The following is a description of a gene set: Human Gene Set: MIKKELSEN_MEF_ICP_WITH_H3K27ME3 Somatic cells can be reprogrammed to a pluripotent state through the ectopic expression of defined transcription factors. Understanding the mechanism and kinetics of this transformation may shed light on the nature of developmental potency and suggest strategies with improved efficiency or safety. Here we report an integrative genomic analysis of reprogramming of mouse fibroblasts and B lymphocytes. Lineage-committed cells show a complex response to the ectopic expression involving induction of genes downstream of individual reprogramming factors. Fully reprogrammed cells show gene expression and epigenetic states that are highly similar to embryonic stem cells. In contrast, stable partially reprogrammed cell lines show reactivation of a distinctive subset of stem-cell-related genes, incomplete repression of lineage-specifying transcription factors, and DNA hypermethylation at pluripotency-related loci. These observations suggest that some cells may become trapped in partially reprogrammed states owing to incomplete repression of transcription factors, and that DNA de-methylation is an inefficient step in the transition to pluripotency. We demonstrate that RNA inhibition of transcription factors can facilitate reprogramming, and that treatment with DNA methyltransferase inhibitors can improve the overall efficiency of the reprogramming process. studied in species Mus musculus from publication Mikkelsen TS, Hanna J, Zhang X, Ku M, Wernig M, Schorderet P, Bernstein BE, Jaenisch R, Lander ES, Meissner A (PMID 18509334) Genes with intermediate-CpG-density promoters (ICP) bearing the tri-methylation mark at H3K27 (H3K27me3) in MEF cells (embryonic fibroblasts)., and this is the list of marker genes: SLC38A5, ART3, HOXB3, TNF, TJP3, CLDN9, RGS8, C1QA, TFAP2B, LEFTY1, SLITRK1, SPATA3, UPK2, CFC1B, EPCIP, PDE11A, KCNIP2, QPRT, CRIPTO, PKHD1L1 (PKHD1 like 1), NCAN, ALOX15B, NKX2-6, BICDL2, ESRP1, UPK3A, HEPACAM2, LTA, SLC24A1, UCP1, COL4A4, C6orf15, LINGO4, FAM149A, CKMT1B, CFAP95, CD72, NOTO, ZIC4, OR2B11, RLN2, MST1, DLG2 (discs large MAGUK scaffold protein 2), SCN9A, KCNJ5, PAMR1, CD40, MOGAT1, RESP18 (NCBI Gene Id 389075), GDAP1L1, PDE1C, SLC28A3, PNOC, ZDHHC22, PLCXD3, ADAMTS16, PVALB, GRB7, CA3, KCND2, MTCL3, ERICH5, NOXA1, CHDH, SULT2B1, NCCRP1, NR5A2, TTLL6, CIITA, BSX, EGF, SOX17, VTN, TNFRSF13C, LRRC23, SLC38A11, EXPH5, PHACTR1, TMEM45B, ODAD1, AQP2, PM20D1, LRRC36, DNAJB13, NPHS1, CHRNG, TMEM184A (transmembrane protein 184A), ARHGAP9, PAX5, GUCA1ANB-GUCA1A, GIPR (NCBI Gene Id 2696), KCNJ9, AQP6, ETV2, SPINT4, ISLR2, KCNMB2, VRTN, CPLX3, LY6G6C, SCN1A, LRRC4B, RYR1, CFAP65, NR5A1, FAIM2, GNAT1, COL4A3, ABCC3, GALNTL6, ADGRG7, CYP1A2, EPN3, C17orf50, ALPI, RASGRP4, ENTPD3, C11orf87, RTBDN, BRINP3, NPY4R, AHSG, PNMA8A, C5, KCNK10, TRIM15, THSD4, ZNF663P, APOA4, LY6G6E, PRR19, ESPN (NCBI Gene Id 83715), CA14, MEF2B, CDH12, SYT3, PIK3CD, TBX22, SLC9A4, FXYD7, SLC25A41, TYMP, NPVF, NSG2, TBATA, KCNN3 (potassium calcium-activated channel subfamily N member 3), FFAR3, LPO, TMEM232, DKK1, STRA6LP, NFE2, GPR84, NRL, PCDH12, FGR, LRRC43, POU2F2, WFDC10A, AVPR1B, TNK1, TDRD1, ATCAY, MALL, HJV, OLAH, MYBPC2, PHYHIP, CALCB, SMTNL1, SYBU, C11orf97, ANKMY1, WNT8B, ELMO1, CD3D, CUTALP, MIOX, TMEM63C, SEZ6L2, GRM3, CHRNB4, HOXB13, SPACA7, KLB, CNTNAP4, NME8, SLFN5, GAS2L2, PDYN, KCNG4, TLR12P, NRG4 (NCBI Gene Id 145957), PRSS16, ARID3B, NRSN2, HESX1 (NCBI Gene Id 8820), PDE8B, ANO4, PRSS36, REN, MC1R, CUX2, GFI1B, TCAM1P, TNFRSF8, EPO